Given this list of marker genes GAA, TMEM63A, TREX1, CCDC115, TMEM175, HPS1, CREG1, PPP3CB, HEXB, SRPX, ATP6V1A, TPCN2, CHMP4B, ATP6V1D, ARL8B, TASL, SLC45A2, TFE3, VPS18, FLCN, CHMP7, CLN6 (CLN6 transmembrane ER protein), RAB7A, SCARB2, RAB14, CHMP1A, MFSD8, ATP6V0B, LAPTM4B, HOOK2, LAMP1, VPS35, SPG11, HOOK1, ATP10B, LAPTM5, ABCA1, RAB39A, AP5Z1, CLN8, NAGPA, CHMP1B, CHMP5, LYSET, CHMP6 (NCBI Gene Id 79643), ATP6AP2, CLVS2, GRN, ACP2, PIKFYVE, TPP1, CHMP4A, MYO7A, TMEM9, BECN1, ZFYVE26, CHMP3, FHIP1B, HOOK3, ZKSCAN3, LRRK2, TCIRG1, TMEM165, SNAPIN, MTOR, ATP6V1H, HPS4, MBTPS1, CLVS1, IRGM, RNASEK, VIPAS39, GNPTAB (N-acetylglucosamine-1-phosphate transferase subunits alpha and beta), LIPA, AP3B1, SPNS1, RAB34, CHMP4C, ARSG, SYT7, HSD17B1, RUFY4, CORO1A, MCOLN1, TMEM199, CHMP2A, ATP6V1F, PI4KB, WASHC5, CHMP2B, TMEM106B, OCA2, PPT1, CLN5, HEXA (NCBI Gene Id 3073), NAGLU, ATP6V0A1, VPS33A, ATP6V0C, RAB7B, CLN3 (CLN3 lysosomal/endosomal transmembrane protein, battenin), ARSB, TFEB, RAB20, LAMTOR1, GBA1, VPS33B, FNIP1, AKTIP, P2RX7, ATP6AP1, PLA2G5, LAMP2 (lysosomal associated membrane protein 2), here is a description of the gene set: A process that is carried out at the cellular level which results in the assembly, arrangement of constituent parts, or disassembly of a lytic vacuole. Human Gene Set: GOBP_LYTIC_VACUOLE_ORGANIZATION studied in species Homo sapiens